The following is a description of a gene set: Enables the transfer of a macromolecule from one side of a membrane to the other. Human Gene Set: GOMF_MACROMOLECULE_TRANSMEMBRANE_TRANSPORTER_ACTIVITY species: Homo sapiens, and this is the list of marker genes: PEX12, TOMM20, ABCC5, SLC15A3, TOMM40, ABCA1 (NCBI Gene Id 8371), TIMM23B, PEX14, SEC61G, TMED10, TIMM22, BLOC1S3, SIDT1, TOMM22, PEX2, AZGP1, MCL1, TIMM17A, TIMM17B, PEX13, TOMM20L, SEC61A2, PEX10, TOMM7, SLC15A4, TOMM40L, SEC63, TIMM23, TOMM70, SIDT2, AP4M1, SEC61A1